The following is a description of a gene set: Effects of SOCS3 on the transcriptional response of bone marrow-derived macrophages to IL-6. Fetal liver cells from SOCS3+/+ or SOCS3-/- embryos were used to reconstitute recipient mice. Donor derived bone marrow from these mice was differentiated to macrophages. Macrophages were either unstimulated, or stimulated for 100 or 400 minutes with 10 ng/ml IL-6. from publication Lang R, Pauleau AL, Parganas E, Takahashi Y, Mages J, Ihle JN, Rutschman R, Murray PJ (PMID 12754506) species: Homo sapiens Genes up-regulated in macrophages with SOCS3 knockout treated by IL6: 100min versus 400min. Human Gene Set: GSE411_100MIN_VS_400MIN_IL6_STIM_SOCS3_KO_MACROPHAGE_UP, and this is the list of marker genes: CRYBB2, LAGE3, ECI1, ZBTB2, MLX, NDUFB7, HMMR, SLC7A6, SLAMF8, G6PD, SEC11C, CDC123, ACBD3, PSPH, CX3CL1, PLA2G4C, MAPRE2, USP15, KIF18A, DIS3L, CD2BP2, CXCL10, UROD, ZDHHC2, VAMP4, LMF2, NMUR1, CDC25C, ARF1, SYN2, UHRF2, COX17, RNF103, PPP2R2D, ATP5PO, RRBP1, PPP2CA, DDIT3, RNF19B, LSR, AK3, TM9SF1, APIP, RTN3, ARHGAP6, PSMA7 (NCBI Gene Id 5688), CXCL9, CISH, IKBIP, GDPD1, THY1, DIPK2A (NCBI Gene Id 205428), DMWD, COX6B1, SMPD1, RPN2, GOLGA3, AARSD1, SH3TC2, PPM1H, ANKRD6, CHCHD3, CHRNB4, SERINC3, NEIL3, UBA3 (ubiquitin like modifier activating enzyme 3), TBL2 (transducin beta like 2), NDUFS6, MAGEH1, FADS1, RHOA, GUK1, REEP4, IER2, CKAP2 (NCBI Gene Id 55221), TIMM29, RIOK3, NANOS1, NDUFB8, CBY1, TIMM17B, CUL2, MBNL2, UQCRQ, SWI5, C4orf46, GLCE, RAD51AP1, MRPL58, SPC25, TINF2, TNFSF10, RNF7, IL20RB, RAB38, ZCCHC18, GMPS, TBRG1, SCCPDH, HSPA14, MCEMP1, CHTF18, PMM1, PRCC, PNPO, GPT2, IL1A, PER1, ZZZ3, RABL6, UBE2G1, MYOM1, STX12, PHGDH, NCKAP1, MRPL15, NFIC, AKAP1, OXR1, BCKDK, PDZD11, SRXN1, SRGN, GSTM3, ARL5A, METTL6, BRWD3, DNAJA3, TNFRSF8, PPP1R11, SHB, AURKA, TESC, TMEM263, TNNT2, UXS1, CTBS, MAB21L3, RAB2A, SH3GLB1, SLC4A1AP, ALG9, YRDC, TAPBPL, GFRA2, LMO4, GALNS, TGFBI, BCL2L14 (NCBI Gene Id 79370), CENPE, BAAT, ZBTB38, SPHK1, CCAR1, CTSE, UBE2L3 (ubiquitin conjugating enzyme E2 L3), CASS4, P2RY14, EBAG9, LRR1, ATF6B, ZNF428, YAE1, SHQ1, HEXIM2, NEK7, MRPS21, TAS1R1, KCNAB2, TMEM147, THYN1, PPP1R10, VCPKMT, PIGB, PIK3R5, SLC35C1, JMJD8, F10, SLC12A4, EIF6, SDHD, CPZ, GOSR2, DNMT3A, CENPK, PSIP1, APP, ARHGAP21, PBK, CPD, DYNC2H1, STX5, MYL2, ASCC3, KIF5C, RAB3D, TBC1D7 (TBC1 domain family member 7), GPSM2, POLR2C, TLK1